Given this list of marker genes XCL1, CORO1A, CCR7, FPR2, CMKLR1, CXCL17, WNT5A (NCBI Gene Id 7474), VEGFC, THBS1, CSF1, P2RY12, VEGFD, CD74, PERP, PTK2B, APP, PLA2G7, CSF1R, GPSM3, MMP14, THY1, TGFB1, CCL24, CXCL13, CCL21, C3AR1, CCL7, ICAM1, RARRES2, MED23, SWAP70, TREM2, CCL19, FUT4, ITGA2, MCU, DEFB124, RIPOR2, SPI1 (NCBI Gene Id 6688), CD47, IL23A, MIA3, C1QBP, CCL1, DAPK2, JAM2, ITGA2B, PTN, ADAM8, PTPRJ, CXCL12, ADAM17, ITGB3, TRPV4, WNK1, CREB3, DEFB131A, RAC2, CCR1, HMGB1, NCKAP1L, MAPK1, FADD, TNFSF18, MDK, CCL4, AIF1, OXSR1, CAMK1D, VEGFB, S100A14, LGMN, PYCARD, MSTN, P2RX4, ADAM10, PIK3R1, CCL20, FUT7, EDN3, DNM1L, ANO6, SLAMF1, RTN4, RAC1, CXCL10, CX3CR1, PLVAP, TMEM102, ABL2, LGALS9, IL12A, LBP, P4HB, C5AR1, CXCL8 (C-X-C motif chemokine ligand 8), IL1R1, CD99, ITGA4, CX3CL1, MAPK3, CCR2, AGER, LGALS3, SELENOK, TIRAP, CCL5, EDN2, S100A7, AKIRIN1, TNFRSF18, RHOA, VEGFA, STK39, ZP3, ZNF580, CCR6, SERPINE1, TNF, EDN1, ABL1, SELE, TNFRSF14, CCL8, F2RL1, CCL2, JAM3, IL6R, IL34, MADCAM1, CD99L2, SPN, XG, KITLG, NEDD9, F7, BDKRB1, GAS6, IL6, THBS4, CALR, LYVE1, SELP, TACR1, PTK2, TNFSF14, ASCL2, MOSPD2, CCL3, PGF, PDGFD, DOCK8, here is a description of the gene set: Human Gene Set: GOBP_POSITIVE_REGULATION_OF_LEUKOCYTE_MIGRATION species: Homo sapiens Any process that activates or increases the frequency, rate, or extent of leukocyte migration.